Given this list of marker genes RND3, MYO18A, LARGE1, STX12, GALNT18, MALL, ZDHHC21, MARCHF4, GOLGA4, TMEM165, SGCZ, INPP5E, SEC16B, GALNT16, FZD5, SYBU, VAPA (NCBI Gene Id 9218), B4GALT6 (beta-1,4-galactosyltransferase 6), SYS1, FUT10, CHST2, CHST3, ATF6, TMBIM1, GALNT14, ZDHHC12, ST6GALNAC1, LPCAT2, SMPD3, B3GNT2, MTCL2, MAN1C1, SNAP29, GNPTAB, KIAA0319L, RAB6B, CSGALNACT2, SORL1, STX16, NDFIP2, B4GALT2, MGAT4A, HLA-DQA1, ABCA7, MAN2A2, COG3, B3GNT6, GALNT7, SLC35A4, CD74, ARL1, TMF1, COPE, SLC30A10, GOLGA2, COG5, CLCN5, STX5, GALNT12, COG1, TAPBPL, PDGFC, SCAMP5, ST6GALNAC6, LALBA, HLA-DRB4, PGAP2, SEC23A, UGCG, SLC35A3, ZDHHC15, HLA-DQA2, OSBP, CHST5, COG7, EXT2, PAQR4, TLR9, ABCA5, ZDHHC20, NDST4, DENND5A, PROS1, PANX2, RAB12, HS3ST3A1, TRAF3IP3, FIG4, TMED9, CHST15, FUT6, ZDHHC5, ATL1, SLC35C1, PCSK5, RAB2B, RAB30 (NCBI Gene Id 27314), TLR8, GCNT2, HPD, RAB29, MYMK, PKD1, CAV1, HACE1, PSEN2, IRGM, TNFRSF1A, SEC16A, PI4KB, GBGT1, GBP3, GOSR2, GOLT1B, IGF2R, SCYL3, CABP1, ST6GAL2, CSGALNACT1, ROCK1, C6orf89, CBFA2T3, HLA-B, CYTH3, GOLPH3 (NCBI Gene Id 64083), UXS1, RAB9A, PIKFYVE, GALNT2, SLC35B4, PSEN1, NCSTN, NRAS, SGCA, LMAN2, PI4K2B, KIF13A, ZDHHC19 (zinc finger DHHC-type palmitoyltransferase 19), FAM20B, SH3GL2, FUT2, TVP23C, RNF125, GCNT4, DOP1A, PAQR3, LARGE2, SNAPIN, CLSTN2, SLC30A5, CAV3, VAC14, ST3GAL6, AP1S1, IFNGR2, ARMH3, COPB2, RHBDF1, B3GNT9, ST3GAL3, CUX1, IER3IP1, BET1L, WLS, AP1M2, TMC6, ZDHHC8, LEPROT, ARHGAP21, STX10, B2M, HHAT, FUT9, FKRP, GOLPH3L, GAL3ST1, CHPF2, MAPKAP1, QSOX2, DSE (NCBI Gene Id 29940), GOLGA1, ST3GAL5, TPST2, AGTRAP, GPR108, TMED7, APH1B, AP1M1, MGAT3, COPG2, CREB3, COG2, ERC1, ARF4, WSCD1, ATP6V1D (NCBI Gene Id 51382), RAP1GAP (NCBI Gene Id 9676), PMEPA1, DRD2, GBA2, SLC35B3, HLA-DPB1, CLSTN3, RXYLT1, SAMD8, PLEKHA3, FUT4, TBC1D20, HLA-DPA1, TAPBP, MPHOSPH9, HS3ST6, MARCHF8, B3GAT1, CHST11, MGAT2, PSENEN, B3GALT9, SCFD1, RFNG, GRINA, TPTE2, ST3GAL1, MAPK8IP3, CAV2, HS2ST1, POMGNT1, ZDHHC3, SLC39A13, ATP2C2, ST6GALNAC4, RASGRP1, TNKS2, AP1B1, HAS2, B4GALT4, FUT5, NOTCH2, GOLT1A, TRIP11, B3GNT3, SLC35A1, GAD2, C1GALT1, CHST6, RIC1, PCSK7, B4GALNT2, FOLR1, ST6GAL1 (NCBI Gene Id 6480), SPRING1, GASK1B, SCARB2, GBF1, NMNAT2, ATP8A2, SEC22B, IHH, RFFL, FKTN, SREBF2, WSCD2, ST6GALNAC3, CRACR2A, TMEM87A, TMEM59, PLA2G4A, NDST3, GALNT9, VPS13B, YIPF6, MGAT4D, GLCE, TLR3, TMEM167A, AP3D1, PGAP4, CLEC2B, ATG9B, GOLGA7B, PTGES2, LLGL1, HLA-DRB1, ATP2C1, CHST8, TRAPPC4, RAB1B, ARFGAP3, MGAT1, TMED10, RAB2A, EBAG9, COP1, RAB11FIP3, GOLGA7, RTN3, GCNT3, NCAM1, CHSY3, SHH, QSOX1, ARFGAP2, USO1, CHST4, STING1, OPTN, SREBF1, B4GALT5, TMCO1, YIF1A, RAB1A, TEX261, PLEKHA8, COPG1, LDLRAD4 (low density lipoprotein receptor class A domain containing 4), ARCN1, TMEM132A, NIPAL1, ST8SIA5, ABCA6, GNAI3, TVP23B, NAA60, COG8, GCNT1, LMTK3, SGMS1, IFT27, B4GALT7, ACBD3, PYCARD, CHP1, KPNA2, UST, NDFIP1, GALNT3, SLC35A5, BET1, SMPD4, MR1, HAS3, PKMYT1, GALNT13, GALNT1, SLC30A1, B3GNT8, EMP2, RRAS2, COG6, GIMAP1 (GTPase, IMAP family member 1), ATP6V1A, B4GALNT1, B3GALNT1, SCARA3, MTOR, LYSMD3, CHST10, SH3GLB1, PARM1, LST1, SLC30A8, RNF175, EXT1, PITPNB, GBP4, RHO, SGMS2, PLPP3 (phospholipid phosphatase 3), AP1S3, TLR7, ASAH2, A4GNT, BLZF1, SGCE, SACM1L, CREB3L3, NOS3, ENTPD4, SLC9A8, ENTPD6, SCAP, AP1S2, GPSM1, RHOD, RGP1, GBP2, SSPN, HS3ST4, SLC26A9, RTN1, DNM2, ZDHHC22 (NCBI Gene Id 283576), LRRK2, HEPACAM2, HUWE1, SLC10A7, SLC30A7, MMD2, MARCHF2 (NCBI Gene Id 51257), GABARAP, HLA-G, PDCD10, LYSET, VTI1A, OTOF, C1GALT1C1, ACER3, LITAF, CHST7, ATP6V1F (NCBI Gene Id 9296), HYAL2, MGAT5B, GPR89A, RAB39A, MYMX, ST8SIA2, SLC35B1, GRM6, B3GALT2, SCOC, DHCR24, MAP4K2, CYTH2, KDELR2, GNPNAT1, TPST1, RAB21, MMGT1, ARF1 (NCBI Gene Id 375), TMEM167B (NCBI Gene Id 56900), LFNG, MGAT4B, RAB14, GLG1, ST8SIA3, B3GNT5 (UDP-GlcNAc:betaGal beta-1,3-N-acetylglucosaminyltransferase 5), SLC50A1, CDC42, TMEM130, GBP1, GOLGB1, HLA-DRA, ZDHHC2, MARCHF9, PLD1, GALNT11, CORO7, PDGFA, COPB1, MAN2A1, PCSK4, SLC2A1, GJA1, ST8SIA1, CASD1, RAB11FIP5 (RAB11 family interacting protein 5), NDST2, DHH, COPZ2, ATP6AP1, CHSY1, INS, CHST9, ST3GAL4, LMAN1, ADAM17, RIC3, FTCD (NCBI Gene Id 10841), WHAMM, MANEA, FUT11, SVIP, NOTCH4, GOLGA3, TRIM23, B3GALT1, ICA1, PRKN, DAG1, CREB3L4, HS6ST2 (heparan sulfate 6-O-sulfotransferase 2), FAM20C, SERINC3, TMEM115, STEAP2, ERGIC3, ARFIP1, MGAT4C, AP1G1, ST8SIA4, GORASP2, MGAT5, YIF1B, MBTPS2, TRAPPC3, HS6ST1, DBNL, HLA-DRB5, CLN3, TMED2, MANEAL, ATP7B, GOLGA5, IL17RD, GCC1, COPA, RAB8A, LPCAT1, GOPC, RHEB, ZDHHC13, FUT8, ST6GALNAC5, SLC35D2, HS3ST2, PI4K2A, CHST13, AP1G2 (NCBI Gene Id 8906), FURIN, CRYZL2P-SEC16B, CYTH1, STX18, B3GAT3, HLA-C, UBIAD1, GLIPR2, ECE2, HS3ST5, SLC35B2, FAIM2, ARF3, TVP23A, MOSPD1, RNF121, CHPF, ARFGEF1, NOTCH1, NOTCH3, GORASP1, CNIH1, GPER1, NAPEPLD, HLA-DQB1, RNASEK, ATP6V0C, IFT20, SLC16A13, UNC50, YKT6, BCAP31, ABCG1, GALNT15, B3GNT7, HLA-A, MAN1A1, HID1, WIPI1, CSPG5, GBP5, RHOU, CHST1, ABCB6, KDELR1, LMAN1L, PDGFB, AGPAT3 (NCBI Gene Id 83745), TMEM87B, PLCE1, VAMP4, ZDHHC4, ERGIC1, TMC8, KDELR3, BSG, HLA-F, HRAS, ACER2, ARL3, ATP6V0B (NCBI Gene Id 533), RNF24, B3GNT4, MAN1A2, CHST14, EGFR, ATP6AP2 (NCBI Gene Id 95880), COG4, GALNT5, ARHGAP32, GALNT4, GALNT6, SGCB, ST8SIA6, B4GALT1, GALNT8, RHBDD2, ARFGAP1, GOSR1, RAB11A, B3GALNT2, ZDHHC17, SLC33A1, HLA-DRB3, ST6GALNAC2, CAMK1G (NCBI Gene Id 89759), SURF4, RAB36, PXYLP1, SYT4, TMBIM4, MBTPS1, GALNTL6, STEAP4, B4GALT3, TNKS, ST3GAL2, APH1A (aph-1 homolog A, gamma-secretase subunit), XYLT2, FUT3, HLA-DQB2, RAB10, CD59, ZDHHC9, APOO, GPR89B, PJA2, ARRB1, FUT7, RAB41, ADAM10, CFP, GALNT10, CHPT1, B3GALT4, GOLIM4, IL15RA, NOSIP, TMEM50B, HLA-H, CLCN3, VPS45, PGAP3, MFNG, STX6, CHST12, SPPL2B, PLD3, LMAN2L, ZDHHC23, XYLT1, DYNAP, HLA-E, ZDHHC7, B3GALT6, FUT1, EEF1AKMT4-ECE2, CD1E, PDGFD, SLC9A7, GALNT17, KRAS, USP32, ASAP1, GFY, QPCTL, ARFGEF2, COPZ1, RAB33B, ZDHHC18, PRKCI, GCNT7, CD55, CYTH4, CLSTN1, ATF6B (activating transcription factor 6 beta), A4GALT, TMEM59L, B3GAT2, NLRP3, TMED3, FNDC3A, TLCD3B, B4GAT1, ABCA12, ZDHHC11, DIPK2A, RAB6A, RER1, B3GALT5, RAB33A, ATP6V1H, SGCD (sarcoglycan delta), HS3ST3B1, ITM2B, RAB26, NDST1, ABO, DOP1B, GABARAPL2, UNC93B1, ATP6V0A2, ATG9A, DSEL, SLC35A2, here is a description of the gene set: Human Gene Set: GOCC_GOLGI_MEMBRANE species: Homo sapiens The lipid bilayer surrounding any of the compartments of the Golgi apparatus.